Given this list of marker genes NECAP2, VPS4A, GABARAPL1, PEX19 (peroxisomal biogenesis factor 19), ABCB9, UBE2D1, SEC23B, CACYBP, SLBP, MCFD2, ADAM28, RNF41, GABARAPL2, COPA, EIF1, RFWD3, RNF187, VPS35 (NCBI Gene Id 91808), USP22, ANG, PDF, EIF4EBP2, TMED2, PACSIN2, EIF2B1, XPOT, EMG1, YME1L1, SEC31A, FBXO21, here is a description of the gene set: Protein biosynthesis, transport or catabolism genes down-regulated in hyperploid multiple myeloma (MM) compared to the non-hyperploid MM samples. from publication Chng WJ, Kumar S, Vanwier S, Ahmann G, Price-Troska T, Henderson K, Chung TH, Kim S, Mulligan G, Bryant B, Carpten J, Gertz M, Rajkumar SV, Lacy M, Dispenzieri A, Kyle R, Greipp P, Bergsagel PL, Fonseca R (PMID 17409404) studied in species Homo sapiens Human Gene Set: CHNG_MULTIPLE_MYELOMA_HYPERPLOID_DN Hyperdiploid multiple myeloma (H-MM) is the most common form of myeloma. In this gene expression profiling study, we show that H-MM is defined by a protein biosynthesis signature that is primarily driven by a gene dosage mechanism as a result of trisomic chromosomes. Within H-MM, four independently validated patient clusters overexpressing nonoverlapping sets of genes that form cognate pathways/networks that have potential biological importance in multiple myeloma were identified. One prominent cluster, cluster 1, is characterized by high expression of cancer testis antigen and proliferation-associated genes. Tumors from these patients were more proliferative than tumors in other clusters (median plasma cell labeling index, 3.8; P < 0.05). Another cluster, cluster 3, is characterized by genes involved in tumor necrosis factor/nuclear factor-kappaB signaling and antiapoptosis. These patients have better response to bortezomib as compared with patients within other clusters (70% versus 29%; P = 0.02). Furthermore, for a group of patients generally thought to have better prognosis, a cluster of patients with short survival (cluster 1; median survival, 27 months) could be identified. This analysis illustrates the heterogeneity within H-MM and the importance of defining specific cytogenetic prognostic factors. Furthermore, the signatures that defined these clusters may provide a basis for tailoring treatment to individual patients.